The following is a description of a gene set: Down-regulated in brown preadipocytes with IRS1 knockout vs wild type controls; the knockouts have severe defects in adipocyte differentiation. The insulin/IGF-1 (insulin-like growth factor 1) signalling pathway promotes adipocyte differentiation via complex signalling networks. Here, using microarray analysis of brown preadipocytes that are derived from wild-type and insulin receptor substrate (Irs) knockout animals that exhibit progressively impaired differentiation, we define genes/expressed-sequence tags whose expression in preadipocytes correlates with the ultimate ability of the cells to differentiate. Many of these genes, including preadipocyte factor-1 (Pref-1) and multiple members of the Wnt signalling pathway, are related to early adipogenic events. Necdin is also markedly increased in Irs knockout cells that cannot differentiate, and knockdown of necdin restores brown adipogenesis with downregulation of Pref-1 and Wnt10a expression. Insulin receptor substrate proteins regulate a necdin-E2F4 interaction that represses peroxisome-proliferator-activated receptor gamma (PPARgamma) transcription via a cyclic AMP response element binding protein (CREB)-dependent pathway. Together these define a key signalling network that is involved in brown preadipocyte determination. from publication Tseng YH, Butte AJ, Kokkotou E, Yechoor VK, Taniguchi CM, Kriauciunas KM, Cypess AM, Niinobe M, Yoshikawa K, Patti ME, Kahn CR (PMID 15895078) Mouse Gene Set: TSENG_IRS1_TARGETS_DN studied in species Mus musculus, and this is the list of marker genes: Ggt5, Ephx1, Mrfap1, Hgf, Igkv4-68, Cirbp, Dab2, Rsad2, Fah, Nfyb, Gja1, Ppl, Mtres1, 4931406C07Rik, Cdkn2c, H2-T10, Cd63, Mmp14, Nmb, Zfr2, Capn6, Sgce, Sntb1 (syntrophin, basic 1), Lifr, Col4a1, Casp2, Gatd3a, Ly6c1, Efnb1, Plpp3, Col6a1, Zfp617, Dennd5a, Sesn1, Pax3, Tnnt3 (NCBI Gene Id 21957), Dkk3, Tnni1, Maoa, Fam50b, Ramp2, Cmbl, Ephb6, Ccdc88a, Snai2, Itih2 (NCBI Gene Id 99064), Ccdc6, Sema3e, Mesd, Zkscan14, Smad6, Fth1, Zfp821, Thbd, Tspan31, Tnnt2, Tnxb, Igfbp4, Crip2, Hsbp1, B3galnt1, Adarb1, Aoc3, Sh3bgr, Mgst3, Limch1, Itpr1, Adam23, Ebf3, Carhsp1, Sfrp2, Tgfbi, Glrx, Psmb5-ps, Prl6a1, Rad52, Tmub2, Diaph1, Hlx, Tapbp, Gas2, Zfhx3, Myl4, Pml, Gstt1, Fabp4, Col3a1 (collagen, type III, alpha 1), Adm, Six1, Il6st, H6pd, Htra3, Cand1, Col4a2, Tle3, Rab3b, Tsc22d1, Hsd17b11, Lpar1, Rasa4, Popdc3, Vsnl1, Cst3, Sirt3, Actc1, Kng1, Sms, Myl1, Zfp637, Fmo1, Enpp1 (NCBI Gene Id 97628), Thra, Trdc, Tspan6, Nrp1, Ctdsp2, Lonp2, Art3, Il1r1, Zfp954, Litaf, Traf3ip2, Rab9 (RAB9, member RAS oncogene family), Pip5k1b, Phka2, Mylpf, Ang2, Frmd6, Tha1, Rbm10, Tmem45a, Gpr37l1, Tnnc1, Col6a3, Ghitm, Trappc12, Hccs, Sparcl1, Tmem185a, Cd40